Given this list of marker genes Cbx3, Krtap3-2, Lpp, Pramel60, Elavl3, C5ar2 (complement component 5a receptor 2), Nr4a2, Mylk4, Ptpn14, Smim33, Abt1, Shisa7, Keap1, Ablim3, Pde4d, Anp32e, Grip1, Vgll3, Znrf2, Bin3, Slc6a19, 4930447A16Rik, Pramel57, Thoc2, Tbc1d13, Frat1, Tent5b, Isg20l2, Cd248, Dnajc3, Dmrta2, Psma5, Adra1a, Zfp213, Clic1, Ifnlr1, Capg, Slc30a2, Hdac8, Krtap12-1, Sdr42e1, Iapp, Nopchap1, Adora3, Xkr4, Or10d5j, Pakap, Cd300ld, Rptor, Zswim8 (zinc finger SWIM-type containing 8), Diras1, Tafa5, Ggnbp1, Clcn4, Edn2, Pspc1, Klf16, Rbak, Zfp282, Nufip2, St18, Steap2, Abl2, here is a description of the gene set: Genes predicted to be targets of miRBase v22 microRNA mmu_miR_6995_3p in miRDB v6.0 with MirTarget v4 prediction scores > 80 (high confidence targets). from publication Chen Y, Wang X (PMID 31504780) Mouse Gene Set: MIR_6995_3P species: Mus musculus